The following is a description of a gene set: The process whose specific outcome is the progression of a glandular epithelial cell over time, from its formation to the mature structure. A glandular epithelial cell is a columnar/cuboidal epithelial cell is a cell found in a two dimensional sheet with a free surface exposed to the lumen of a gland. species: Mus musculus Mouse Gene Set: GOBP_GLANDULAR_EPITHELIAL_CELL_DEVELOPMENT, and this is the list of marker genes: Pgr, Gata2, Spdef, Rarb, Gpat4, Rarg, Bhlha15, Fzd5, Slc9a4, Xbp1, Rara, Hif1a